The following is a description of a gene set: part of: Chromatin modifying enzymes studied in species Mus musculus This event has been computationally inferred from an event that has been demonstrated in another species.<p>The inference is based on the homology mapping from PANTHER. Briefly, reactions for which all involved PhysicalEntities (in input, output and catalyst) have a mapped orthologue/paralogue (for complexes at least 75% of components must have a mapping) are inferred to the other species. electronically inferred by orthology from the curated human pathway Reactome Pathway: RMTs methylate histone arginines, and this is the list of marker genes: Smarcd2, Smarcc2, H4c14, H3c10 (H3 clustered histone 10), H4c12, Smarcb1, H2ac15, H2ac6, H4c2, H2ac25, H3c8, H3c3, H4c17, Smarca4, H2ac24, H2ac23, Rbbp7, Carm1, Cdk4, H3c4, H2ac4, H4c6, Prmt3, H3c6, H2ac22, H2ac13, H3c1, Smarca2, Rps2, H3c11, H3c13, H3c7, H2ac20, H2ac1, H4c9, Ccnd1, H2ac8, Arid1a (AT-rich interaction domain 1A), H4c3, Smarcd1, H4c18, H3c2, H4c4, H4c11, H2ac19, H2ac12, H4c1, H2ac11, H2ac10, H4c8 (H4 clustered histone 8), Actl6b, H2ac7, Smarcc1, H3c15, Prmt5